Given this list of marker genes MIR138-1, PARP1 (poly(ADP-ribose) polymerase 1), TRPM4, FAM83A (NCBI Gene Id 84985), POU4F2, GHRL, NCOA2, SORL1, NCOA1 (NCBI Gene Id 8648), INHBE, SPI1, PRKAA1, LPL, PLAAT3, SIRT1, KLF7, PPARG (NCBI Gene Id 5468), NR1H4, here is a description of the gene set: studied in species Homo sapiens Any process that modulates the frequency, rate or extent of adipose tissue development. Human Gene Set: GOBP_REGULATION_OF_ADIPOSE_TISSUE_DEVELOPMENT